The following is a description of a gene set: Both turbulent (disturbed) flow and low laminar flow across epithelial cells initiate an inflammatory response that causes atherosclerosis. In vivo, this process makes curved and branched regions of arteries especially prone to atherosclerosis.<br>In endothelial cells, fluid flow is sensed by mechanoresponsive membrane-localized PIEZO1 channels, which open and cause an influx of cations including calcium ions (Ca2+) (inferred from the mouse homolog in Conte et al. 2010). Intracellular Ca2+ activates the protease complex Calpain2, which cleaves Vinculin (VCL), a component of the peripheral cytoskeleton located between integrins and actin fibers. Turbulent flow across endothelial cells also causes release of ATP by an uncharacterized mechanism.<br>Through an uncharacterized PIEZO1-dependent mechanism, the phosphatase PTPN1 (PTP1B) is activated to dephosphorylate Annexin-2 (ANXA2), which relocalizes with integrins (ITGA5:ITGB1) to lipid rafts in the cell membrane. The integrins recruit the phosphodiesterase PDE4D5 and the phosphatase PP2A, which activates PDE4D5 by dephosphorylating serine-715 and activates YAP1 by dephosphorylating serine-127 (inferred from mouse homologs in Yun et al. 2016). Activated PDE4D5 hydrolyzes cAMP and thereby increases inflammation. YAP1 is phosphorylated by ABL1 on tyrosine-407 and transits to the nucleus to activate pro-inflammatory genes.<br>The kinase PTK2 (focal adhesion kinase, FAK) is phosphorylated, likely through autophosphorylation, and then activates pro-inflammatory NF-κB signaling through phosphorylation of CHUK (IKKA) and RELA. IKBKE is phosphorylated by an uncharacterized mechanism and phosphorylates STAT1, which dimerizes and transits to the nucleus to activate pro-inflammatory genes such as NLRP3. studied in species Homo sapiens Reactome Pathway: Turbulent (oscillatory, disturbed) flow shear stress activates signaling by PIEZO1 and integrins in endothelial cells part of: Response of endothelial cells to shear stress, and this is the list of marker genes: YAP1, PPP2R1B, CAPNS1 (NCBI Gene Id 826), PPP2R1A, CAPNS2, ITGA5, CAPN2, PIEZO1, IKBKB (inhibitor of nuclear factor kappa B kinase subunit beta), FN1, PPP2R2A, CHUK, RELA, IKBKE, ABL1, ITGB3, VCL, STAT1, NFKBIA, GNAQ, NFKB1, PTPN1, IKBKG, ITGAV, ITGB1, GNA11, PDE4D, PPP2CA, PTK2, ANXA2, NLRP3